Given this list of marker genes GIGYF2, FAM219B (family with sequence similarity 219 member B), TTC14, PPP4R2, LINC00511, GNPDA2, ERBIN, GOLGA1, MED8, FAM50A, GTF2IRD2, CREBL2, TMEM127, PAK1IP1, NDUFA6, SRXN1, ZBTB48, VPS13D, JAK2, OCIAD1, CCDC82, F2R, PNPLA7, CARD11 (caspase recruitment domain family member 11), MROH1, SLAMF6, RNF215, TECR, MMP24, WASHC3, KCTD2, SIAH1, RECK, IL1R2, CHD7, TMCC3, PIGC, TASOR (transcription activation suppressor), GOLM1, PLPP6, CAB39L, S100A13, CD48, LYRM1, HLA-DRB1, MIB2 (MIB E3 ubiquitin protein ligase 2), DYNC1H1, PANK4, KIDINS220, OS9, CLCN4, WSB2, CD3E, TTC28, L1CAM, LAMTOR2, FAAH, DMTF1, KIAA0040, PAPOLG, PPM1K, PPCS (NCBI Gene Id 79717), UCKL1, SDF4, TMEM129, IGF2R, MIA3, DNAJC15, LIMK2, DOK2, FAM89B, LAIR1, CMTM6, USP24 (ubiquitin specific peptidase 24), HBP1, TAFAZZIN, VAV1, TBCE (tubulin folding cofactor E), PLEKHJ1, CHMP1A, EVI2B, IL4, TPP1, NXF1, HLA-DMA, HLA-DQA1, PKN1, YPEL3, TTC3, GBP7, PRSS55, CTU1, AKT3, AP2A2, PDLIM1, RAF1, TNKS2, ATG2A, OSBPL7, STAT5B, TBX21, CNP, ADAMTSL4, NEMF, OAS3, CHMP5, PSEN2, AQP9, SMURF2, NSMCE3, SLC49A4, ZNF703, RASL11B, NAA60, TAF1C, UGGT1, CLEC4M, HLA-E, BSG, CD6, MAEA, TRAF3, MTERF1, STAT4, OSTM1, DUSP12, HERC2, STIM2, C1QB, STK38, FAM149B1, ITPR3, SEPTIN7, TMEM63B, RIT1, SPO11, NCOA2, JUND, NAB2, ECM1, KEL, GTPBP6, CYSLTR2, TNRC6C, C1orf122, RNF146, NSD3, TBK1, GINM1, TSGA13, ABHD1, RMND1, TNFAIP8L2, XDH, DAPL1, INTS6L, OSM, PRDM1, IFIT3, EBI3, AKNA, ZNF2, IFIH1 (NCBI Gene Id 64135), RTN1 (reticulon 1), TRAK2, ZBTB9, CCPG1, EYA2, RPS6KA4, YOD1, DOCK8, REXO4, CDCP1, C3orf80 (chromosome 3 open reading frame 80), CD300C, CYB5R4, EPAS1, KLRG1, SELENOO, PDCD1, BLOC1S1, SERINC1, KDM5B, RAB20, EEF1AKMT1, FAM117B, GOLT1A, ZFAND6, AGPAT3, AR, RIGI, CAPN2, ITPR2, EID2, SEC16B, SETX (senataxin), SMURF1, CALCOCO1, TLE5, here is a description of the gene set: Human Gene Set: GSE10273_HIGH_VS_LOW_IL7_TREATED_IRF4_8_NULL_PRE_BCELL_DN Productive rearrangement of the immunoglobulin heavy chain locus triggers a major developmental checkpoint that promotes limited clonal expansion of pre-B cells, culminating in cell cycle arrest and rearrangement of the kappa (κ) or lambda (λ) light-chain loci. B lineage cells lacking the related transcription factors IRF-4 and IRF-8 undergo a developmental arrest at the cycling pre-B cell stage and are blocked for light-chain recombination. Using Irf-4,8-/- pre-B cells we demonstrate that two pathways converge to synergistically drive light-chain rearrangement, a process that is not simply activated by cell cycle exit. One pathway is directly dependent on IRF-4, whose expression is elevated by pre-BCR signaling. IRF-4 targets the κ 3′ and λ enhancers to increase locus accessibility and positions a kappa allele away from pericentromeric heterochromatin. The other pathway is triggered by attenuation of IL-7 signaling and results in activation of the κ intronic enhancer via binding of the transcription factor, E2A. Intriguingly, IRF-4 regulates the expression of CXCR4 and promotes the migration of pre-B cells in response to the chemokine CXCL12. We propose that IRF-4 coordinates the two pathways regulating light-chain recombination by positioning pre-B cells away from IL-7 expressing stromal cells. We used microarrys to identify the changes in gene expression under different levels of the cytokine IL-7 and after rescue of genetic defect. species: Homo sapiens Genes down-regulated in IRF4 and IRF8 null pre-B cells treated with IL7: 5 ng/ml versus 0.25ng/ml. from publication Johnson K, Hashimshony T, Sawai CM, Pongubala JM, Skok JA, Aifantis I, Singh H (PMID 18280186)